The following is a description of a gene set: Increased susceptibility to otitis media, as manifested by recurrent episodes of otitis media. studied in species Homo sapiens Human Gene Set: HP_RECURRENT_OTITIS_MEDIA Recurrent otitis media, and this is the list of marker genes: SPEF2, ANAPC1, COBLL1, AP3B1, DNAL1, CD79B, BTK, UBB (ubiquitin B), PRKAR1B, MCIDAS, ZMYND10, TAOK1, HYDIN, DOCK11, TNFRSF13C, IL6R, ADA (NCBI Gene Id 100), FOCAD, RPGR, STIM1, RIC1, MEG3, DPP9, PIK3CD, CFAP74, TMCO1, DNAAF6, ICOS, COL2A1, LIG4, SMARCD2, CCNO, CBLB, POLR3A, CCDC47, COL11A1, IGKC, ZEB2, CDC42BPB, PRKCD, TP63, AGR2, DNAAF4, CCDC65, NFKB2, RNU4-2, ODAD4, CD28, OFD1, RAP1B, NECTIN1, RTL1, CD3E, SLC35C1, SETD2, PTEN, DHCR7 (7-dehydrocholesterol reductase), SYK, PDGFRA, DRC1, DNAI2 (dynein axonemal intermediate chain 2), PSMD12, TAF4, LIG1, ACP5, ELN, BMP4, IDUA, STK36, DNAH11, RELB, TCF3, ODAD3, FCGR3A (NCBI Gene Id 2214), IKBKB (inhibitor of nuclear factor kappa B kinase subunit beta), GNB2, H4C3, RAC2, MED12, GRHL3, DAW1, DLX4, RAI1, SMG9, ODAD1 (outer dynein arm docking complex subunit 1), FBXO11, DEAF1, ARHGEF38, C1QB, NBN, MGP, C4B, CCDC40, NCKAP1L, SH3KBP1, GLRA2, IL2RB, NFKBIA, ZNF341, DLG1, DOCK2, CD4, AIRE, H4C5, DNAAF1, PHIP, RSPH4A (radial spoke head component 4A), USP26, ATN1, HEPHL1, TBX1, TTC12, IGLL1, DOCK8, PCYT1A, PGM1, RNU4ATAC, TPP2, NAA10, CFAP221, CD3G, EYA4, DNAH1, INSR, IDS, RPL11, GNPTAB, MAPK1, MNS1, KDM6A, CCDC103, CFI, ADA2, DNAI1, FOXP1, CFAP300, NME8, MLXIPL, USB1, TNFRSF13B (TNF receptor superfamily member 13B), MAP3K7, ICOSLG, WAS, TRAC, FOXJ1, ODAD2, CCDC39, SRCAP, POGZ, RNF2, DNAH9, IL21R, DNAAF3, SDCCAG8, BPTF, IL7R, CFAP298, FMR1, IL17RA, A2ML1, CDH1, FLII, JAGN1, FLNA, KMT5B (lysine methyltransferase 5B), IGHG2, IGHM, CD19, SLC37A4, PIK3CG, TFE3, DDB1, GAS2L2, NSUN2, THRB, BAP1, DNAAF11, CORO1A, POLR1A, FGFR3, LRRC56, IQSEC2, CR2, SEC61A1 (SEC61 translocon subunit alpha 1), HYAL1, DNAAF2, LRBA, TNRC6B, SPAG1, CD79A, SRY, ARHGAP29, CEBPE, PSMB8, PLCG2, RFXAP, CD3D, GNS, MAGT1, RSPH3, PDCD1, DPF2, RFX5, RSPH1, BCOR, DNAJB13, UNC119, WDR26, FZD2, CDCA7, IL6ST, TLR8, MSX1, ADAT3, LBR, KMT2D, KMT2A, RAC1, DNAAF5, NME5, JAK3, GUSB, IRF6, KIF15, KAT6A, GAS8, BLNK, CFAP52, IKBKG, NEK10, PIK3R1, DYRK1A, KANSL1, RSPH9, DLK1, DNAH5